The following is a description of a gene set: Any process that stops, prevents, or reduces the frequency, rate or extent of cell death by apoptotic process in neurons. studied in species Homo sapiens Human Gene Set: GOBP_NEGATIVE_REGULATION_OF_NEURON_APOPTOTIC_PROCESS, and this is the list of marker genes: IL27RA, GDF5, LGMN, SOD1, GRIK2, TYRO3, SLC1A1, SET, ZPR1, PTPRZ1, PSEN1, TFAP2D, SEMA3E, AXL, FGF2, MIR132, GPRASP3, CHL1, CX3CL1, CLCF1, AARS1, EN1, NGF, SIX4, HTRA2, HIPK2, SOD2, NR4A3, IL10, CNTF, UCP2, ERBB3, MIR15B, BARHL1, ATF4, PLXND1, GRN, KIF14, NES, FZD1, AMBRA1, NR4A2, CRLF1, TFAP2B, BCL2, KRAS, RHOA, CITED1, CBLC, BCL2L1, NTRK2, PPARGC1A, SNCA, CCND1, KDM2B, PTK2B, FGF20, RASA1, GDNF, SLC25A27, SIRT1, MECP2, CTNNB1, ADAM8, PRKCG, MSH2, ALKBH1, NMNAT1, NFATC4, SYNGAP1, LIG4, NTRK1, PIK3CA, AGAP2, CEBPB, XRCC2, TOX3, TP73, NRBP2, KDR, BAX, OXR1, MDK, MIR212, PPT1, GBA1, MAG, GBE1, DNAJC5, NTF4, WFS1, CLU, IL6ST, POU4F1, BRAF, VSTM2L, MIR195, TMBIM1, VPS54, BDNF, STAMBP, MT3, UCN, NAIP, PCDHGC4, UNC5B, RETREG1, MIR181C, DRAXIN, JUN, HRAS, CNTFR, STXBP1, FZD9, BBS10, DLX1, FYN, CLN8, FOXB1, WNT1, FAIM2, PLA2G3, CX3CR1, SIX1, SNX6, ADORA2A (adenosine A2a receptor), PCDHGC5, ATP7A, HYOU1, PRKCI, PYCR1, NDNF, FBXO7, JAK2, GCLM, FGF8 (NCBI Gene Id 2253), NRP1, VEGFB, LCN2, AKT1, CLN3, CPEB4, PRKN (parkin RBR E3 ubiquitin protein ligase), PINK1, MFSD8, MAP3K12, EPHA4, RAD21, HIF1A, NONO, GCLC, NTF3, HSPG2, TGFB3, FPR2, NPPC, ROCK1, CD2AP, MEF2C, NEFL (neurofilament light chain), LONRF2, CORO1A, BOK, PARK7, PCDHGC3, ARMCX5-GPRASP2, ADNP, GFRAL, CCL2, BTG2, ISL1, ANGPT1, THAP11, TMBIM4, SNCB, F2R, EN2, MAP2K4, MTNR1B, GRINA, TERT